The following is a description of a gene set: species: Homo sapiens “Memory-like T cells” are a subset of thymic cells that acquire effector function through the maturation process rather than interaction with specific antigen. Disruption of genes encoding T cell signaling proteins or transcription factors have provided insights into the differentiation of such cells. We show here that in BALB/c but not C57BL/6 mice, a large portion of thymic CD4-CD8+ T cells exhibit a memory-like phenotype. In BALB/c mice, IL-4 secreted by invariant natural killer T (iNKT) cells is both essential and sufficient for the generation of memory-like T cells. In C57BL/6 mice, iNKT cells are less abundant, producing IL-4 that is insufficient to induce thymic memory-like CD8+ T cells. BALB/c mice deficient in the transcription factor Kruppel-like factor (KLF) 13 have comparable numbers of iNKT cells to C57BL/6 mice and extremely low levels of thymic memory-like CD8+ T cells. This work documents the dramatic impact of a small number of KLF13-dependent iNKT cells. Human Gene Set: GSE25502_WT_VS_KLF13_KO_THYMIC_MEMORY_LIKE_CD8_TCELL_DN Genes down-regulated in thymic memory like CD8 cells: wildtype versus KFL13 knockout. from publication Lai D, Zhu J, Wang T, Hu-Li J, Terabe M, Berzofsky JA, Clayberger C, Krensky AM (PMID 21482696), and this is the list of marker genes: KIR3DL1, SLC19A1, CPNE7, GJA3, FLJ13224, HOXC11, KCNH4, LINC02912, ABHD17A, NRAP, UBXN11, MGARP, SLCO1B1, POLR3D, NKAPL, AGR3, SPSB3, CACNG4, PROM1, ATOH8, KLK8 (NCBI Gene Id 116193), LINC02532 (NCBI Gene Id 553137), RNF133, SIGLEC5, ZBTB46, OLFML1, CCM2L, LUZP2, CLU, GIMAP4, VSNL1, TSC22D1-AS1, TBC1D9, SULT2A1, NAAA, SUN5, DLL4, SLC24A3, CCDC42, PRB4, ZNF473CR, SRGAP3, MIR124-1HG, MEG3, GRID1, TEX44, OR51B2 (olfactory receptor family 51 subfamily B member 2), OOSP2, POSTN, PALD1, EXOC3L1, FGF10, PRAC2, THSD7A, BTN2A3P, NSFL1C, ZMYND15, ATF7, PRDM1, LINC00293, UNC13B, NKG7, COX7B2, SPAG8, SMIM11, WNT10A, TAFA2, SCD, PCDHGA10, KLK6, C19orf84, MYPN, GJA5 (gap junction protein alpha 5), CHPF, NPSR1-AS1, CFAP95-DT (NCBI Gene Id 494558), KRT9, NUDT7, SLFNL1, WNT5A (NCBI Gene Id 7474), TEAD3, MVK (mevalonate kinase), SLC22A8, TRPV4, LRRTM1, LAMC3, MARCO, PLCL1, DNM1P46, STXBP5-AS1, FAM78B, TRPC5OS, SEPTIN4, BRSK1, GML, CSN3, CYP2S1, OR2C3, ANKRD40CL (ANKRD40 C-terminal like), SQSTM1, GP1BB, PRSS23, AQP9, ESRRA, SH3GL1P2 (NCBI Gene Id 6459), ZMYND10, STAC2, RTEL1, ENSG00000229727, NECTIN4, LRRC19, RFPL1, GPR4, THBS4, NCAPH2, CYP8B1, AMHR2, AP5B1, ASB16, GP2, NME8, CFAP45, MUC2, PRB1, CRISPLD1, ADRB3, PCSK4, SEC14L2 (SEC14 like lipid binding 2), TMEM232, WFDC10B, QRFPR, MTTP, SGTA, NACC2, MARVELD1, RGMB, PC, FCAR, RBP4, DYSF, NUDT16-DT, TMPRSS4, CRYBB1, TRAPPC14 (trafficking protein particle complex subunit 14), ASB14, SREBF2, DNAL1, FOXL2, H4C9, CYTL1, FCHO2, CD33, DRD5, CCNYL7, HPCA, ENSG00000288891, APBA3, LINC03124, OR6W1P, GNAT2, RHPN1, LHX9, HIF3A, CNTN2, TCERG1L, GRK2, PACS2, TPRXL, HERC2P1, ZFP2, FAM216B, ELOVL4, NECTIN2, ZNRF4, PRODH2, SSH2 (NCBI Gene Id 85464), ADAMTS16, VSIG4, RAI1, PCP4, LRRC36 (NCBI Gene Id 55282), GCAT, B4GALNT2 (beta-1,4-N-acetyl-galactosaminyltransferase 2 (SID blood group)), NMNAT2, KAZALD1, LINC01541, SEMA6C, SLC4A3